The following is a description of a gene set: Human Gene Set: LANDIS_BREAST_CANCER_PROGRESSION_DN from publication Landis MD, Seachrist DD, Abdul-Karim FW, Keri RA (PMID 16434967) Genes down-regulated in preneoplastic mammary tissues and whose expression is maintained in tumors. Epidemiological studies indicate that parity enhances HER2/ErbB2/Neu-induced breast tumorigenesis. Furthermore, recent studies using multiparous, ErbB2/Neu-overexpressing mouse mammary tumor virus (MMTV-Neu) mice have shown that parity induces a population of cells that are targeted for ErbB2/Neu-induced transformation. Although parity accelerates mammary tumorigenesis, the pattern of tumor development in multiparous MMTV-Neu mice remains stochastic, suggesting that additional events are required for ErbB2/Neu to cause mammary tumors. Whether such events are genetic in nature or reflective of the dynamic hormonal control of the gland that occurs with pregnancy remains unclear. We postulated that young age at pregnancy initiation or chronic trophic maintenance of mammary epithelial cells might provide a cellular environment that significantly increases susceptibility to ErbB2/Neu-induced tumorigenesis. MMTV-Neu mice that were maintained pregnant or lactating beginning at 3 weeks of age demonstrated accelerated tumorigenesis, but this process was still stochastic, indicating that early pregnancy does not provide the requisite events of tumorigenesis. However, bitransgenic mice that were generated by breeding MMTV-Neu mice with a luteinizing hormone-overexpressing mouse model of ovarian hyperstimulation developed multifocal mammary tumors in an accelerated, synchronous manner compared to virgin MMTV-Neu animals. This synchrony of tumor development in the bitransgenic mice suggests that trophic maintenance of the mammary gland provides the additional events required for tumor formation and maintains the population of cells that are targeted by ErbB2/Neu for transformation. Both the synchrony of tumor appearance and the ability to characterize a window of commitment by ovariectomy/palpation studies permitted microarray analysis to evaluate changes in gene expression over a defined timeline that spans the progression from normal to preneoplastic mammary tissue. These approaches led to identification of several candidate genes whose expression changes in the mammary gland with commitment to ErbB2/Neu-induced tumorigenesis, suggesting that they may either be regulated by ErbB2/Neu and/or contribute to tumor formation. studied in species Mus musculus, and this is the list of marker genes: PPP2R5A, VWF, ALAS1, COL4A1, ETFB, IGFBP6, FSTL1, KLF4, COL5A1, ST3GAL6, ACAA1, ANGPTL2, LAMB1, CIDEC, CXCL12, PGM1, IDH1, NRP1, PDE8A, UCK1 (NCBI Gene Id 83549), THBD, TGFBI, GPAM, QKI, CD34, GNAI1, H6PD, AHNAK, HEPH (hephaestin), FZD4, DHRS7, CRIP1, MAP4, S100A6, SORBS1, RAB34, DGAT1, SRPX, CLEC3B, MFNG, DECR1, SQOR, LUM, HTRA1, GAS6, ALAD, GJA1, PLAC8, EPHX2, HSPB8, FEZ2, NR1H3, SULT1A1, DERL1, ZEB1, BCKDHB, PHYH, MRC1, DPEP1, COL6A3, BNIP2, MAN1A1, COL18A1, COL3A1, CCDC80, COL1A1, CAVIN3, DPT, ADIG, ADIPOR2 (adiponectin receptor 2), PENK, GHR